Given this list of marker genes COL3A1, TWIST1 (NCBI Gene Id 7967), GPC6, TEAD3, MIR509-3, BCAR1, PBX3, TEAD2 (TEA domain transcription factor 2), TEAD1, SNAI2, SPARC, THBS2, FN1, COL1A1, YAP1, TEAD4, EDNRA, COL5A1, here is a description of the gene set: miR-509-3p alteration of YAP1/ECM axis Human Gene Set: WP_MIR5093P_ALTERATION_OF_YAP1ECM_AXIS species: Homo sapiens